Given this list of marker genes Pigk, Pigs, Pigu, Gpaa1, Pigt, here is a description of the gene set: species: Mus musculus Mouse Gene Set: GOCC_GPI_ANCHOR_TRANSAMIDASE_COMPLEX An enzyme complex which in humans and yeast consists of at least five proteins; for example, the complex contains GAA1, GPI8, PIG-S, PIG-U, and PIG-T in human, and Gaa1p, Gab1p, Gpi8p, Gpi16p, and Gpi17p in yeast. Catalyzes the posttranslational attachment of the carboxy-terminus of a precursor protein to a GPI-anchor.